Given this list of marker genes BTK, RAD23B, STAT5A, PDIA3, IL2RG, P4HB, TSLP, IL7R, JAK3, YBX1, IL7, HSPD1, LSP1, HMGB1, FOSL2, GIPC1, ATIC, ATP5F1B, STAT1, STIP1 (stress induced phosphoprotein 1), CRKL, JAK1, here is a description of the gene set: Human Gene Set: GOBP_RESPONSE_TO_INTERLEUKIN_7 Any process that results in a change in state or activity of a cell or an organism (in terms of movement, secretion, enzyme production, gene expression, etc.) as a result of an interleukin-7 stimulus. species: Homo sapiens